The following is a description of a gene set: Reactome Pathway: Activation of Ca-permeable Kainate Receptor part of: Ionotropic activity of kainate receptors species: Mus musculus electronically inferred by orthology from the curated human pathway This event has been computationally inferred from an event that has been demonstrated in another species.<p>The inference is based on the homology mapping from PANTHER. Briefly, reactions for which all involved PhysicalEntities (in input, output and catalyst) have a mapped orthologue/paralogue (for complexes at least 75% of components must have a mapping) are inferred to the other species., and this is the list of marker genes: Dlg3, Calm1, Grik5, Dlg4